Given this list of marker genes SIX4, GATA3, GDNF, GREM1, HS2ST1, SIX1, NOG, here is a description of the gene set: species: Homo sapiens The developmental process pertaining to the initial formation of the ureteric bud from the Wolffian duct. This process begins when the bud protrudes from the duct and ends when it is a recognizable bud. Human Gene Set: GOBP_URETERIC_BUD_FORMATION